The following is a description of a gene set: Human Gene Set: HE_LIM_SUN_FETAL_LUNG_C0_MESENCHYMAL_3_CELL from publication He P, Lim K, Sun D, Pett JP, Jeng Q, Polanski K, Dong Z, Bolt L, Richardson L, Mamanova L, Dabrowska M, Wilbrey-Clark A, Madissoon E, Tuong ZK, Dann E, Suo C, Goh I, Yoshida M, Nikolić MZ, Janes SM, He X, Barker RA, Teichmann SA, Marioni JC, Meyer KB, Rawlins EL (PMID 36493756) species: Homo sapiens Mesenchymal 3, and this is the list of marker genes: CDC42EP3, SPINT2, LDB2, B3GALT6 (NCBI Gene Id 126792), ASS1, ADM, PDE3A, SERPINF1, NUDT14, SULF2, CAMK1D, IGF2-AS, ZFHX4, TWIST1, PITPNC1, MEIS2, IGLON5, SPSB1, TMEM132A, PTGIS, WT1, FST, FLRT2, AMOTL2, EDN3 (NCBI Gene Id 1908), ITGB8, DLK1, LY6H, INHBA, DACT1, CA10, CLCN5 (chloride voltage-gated channel 5), PINK1, TUBB2B, TMEM54, TMEFF2 (NCBI Gene Id 51753), CSRP2 (NCBI Gene Id 7882), SERINC2, FZD2, PDPN, PLCL1, GRAMD1A, TENM4, COL26A1, CD24, STRA6, PEG3, P3H2, FBN2, ALCAM, FBN3, MCC, CTHRC1, SMOC2, HOXA4, KRT18, AMOT, PDXK, HGF, XIST, GAS2, EFNB2, TPBG, TRIO, TES, COL25A1, P3H3, AKR1C2 (NCBI Gene Id 6994), SCUBE3 (NCBI Gene Id 222663), MN1, COL11A1, EFNA1, RELN, KLF7, RPRM, MMP11, IQCA1, TIPARP (NCBI Gene Id 25976), UCHL1, GJA1, RHOD, TCEAL5, RASL11B, EPHA7, PRRX1, CCDC102A, ASPN, ADAMTS10, KCNQ2 (potassium voltage-gated channel subfamily Q member 2), SNAI1, TOMM34, ITM2A, KRT8, CRABP2, BST2, ZNF579, DHRS3, MEIS3, PTX3, NET1, SLC38A1, CFAP68, TM4SF1, EPHB2, CFI, LRRN1, DOCK11, CRABP1, BEX2, PITX2, DMKN, CDON, TMEM200A, EPHA3, TECRL, TMEFF1, IGFBP2, LINC02381, ADAMTSL1, ANOS1, IER5L, PDLIM4, PODXL2, MPPED2 (NCBI Gene Id 744), EBF2, PDGFD, IQGAP2, APLP1, SVIL, SH3BP5, EPHB3, EFNA5, BEX1, NKAIN3, RNF207, MXRA5 (matrix remodeling associated 5), OLFM2, BCL11A, ITGA5, PACC1, TENM3, FLNB, CCDC3 (NCBI Gene Id 83643), ZEB1, GATA4, PRKD1, FOXP4, C2orf88, CD74, CDC34, COL9A3, ANK3, RSPO3, ADAMTS9, FHL2, RAC2, SIGIRR, OCIAD2, EPHA4, SYCE1L, MIR503HG, KIF26B, CDH2, ADRB3, LIN7A, MIR99AHG, NRXN1, CNTN4, CLUL1, HMGA2, FLNC, COL2A1, KIF21A, CADM4